The following is a description of a gene set: studied in species Mus musculus Genes positively differentially expressed in cell type: Macrophage upon treatment with cytokine: IL-2 in mouse lymph nodes in vivo. from publication Cui A, Huang T, Li S, Ma A, Pérez JL, Sander C, Keskin DB, Wu CJ, Fraenkel E, Hacohen N (PMID 38057668) Mouse Gene Set: CUI_MACROPHAGE_IL2_RESPONSE_UP Cytokines mediate cell-cell communication in the immune system and represent important therapeutic targets. A myriad of studies have highlighted their central role in immune function, yet we lack a global view of the cellular responses of each immune cell type to each cytokine. To address this gap, the authors created the Immune Dictionary, a compendium of single-cell transcriptomic profiles of more than 17 immune cell types in response to each of 86 cytokines (>1,400 cytokine-cell type combinations) in mouse lymph nodes in vivo. A cytokine-centric view of the dictionary revealed that most cytokines induce highly cell-type-specific responses. For example, the inflammatory cytokine interleukin-1β induces distinct gene programmes in almost every cell type. A cell-type-centric view of the dictionary identified more than 66 cytokine-driven cellular polarization states across immune cell types, including previously uncharacterized states such as an interleukin-18-induced polyfunctional natural killer cell state., and this is the list of marker genes: Lcp2, Ccl7, Cxcl10, Ifi204, Serpina3g, Eif1a, Ptpn1, Irf1, Pnp, Cxcl9, Max, Ubd, Fam241a, Ccl12, Gbp2, Samhd1, Tma16, Serpina3f, Rnf19b, Ifi205, Calhm6 (calcium homeostasis modulator family member 6), Ifi203 (NCBI Gene Id 15950), Stat1, Iigp1, Igtp, Sod2, Gbp7, Cdkn1a, Ifi47, Bcl2a1b, Mndal, Ccl2, Socs1 (suppressor of cytokine signaling 1), Ifi211, Irgm1, Gbp5